The following is a description of a gene set: Any process that modulates the rate, frequency, or extent of the wakeful phase of the circadian sleep/wake cycle. The wakeful phase is the part of the circadian sleep/wake cycle where the organism is not asleep. species: Mus musculus Mouse Gene Set: GOBP_REGULATION_OF_CIRCADIAN_SLEEP_WAKE_CYCLE_WAKEFULNESS, and this is the list of marker genes: Nlgn1, Uts2r, Ptger3, Uts2, Nps, Ptger4, Hcrtr2